The following is a description of a gene set: Genes specific to BEC (blood endothelium cells) repressed in BEC by expression of PROX1 off adenovirus vector. Lymphatic vessels are essential for fluid homeostasis, immune surveillance and fat adsorption, and also serve as a major route for tumor metastasis in many types of cancer. We found that isolated human primary lymphatic and blood vascular endothelial cells (LECs and BECs, respectively) show interesting differences in gene expression relevant for their distinct functions in vivo. Although these phenotypes are stable in vitro and in vivo, overexpression of the homeobox transcription factor Prox-1 in the BECs was capable of inducing LEC-specific gene transcription in the BECs, and, surprisingly, Prox-1 suppressed the expression of approximately 40% of the BEC-specific genes. Prox-1 did not have global effects on the expression of LEC-specific genes in other cell types, except that it up-regulated cyclin E1 and E2 mRNAs and activated the cyclin e promoter in various cell types. These data suggest that Prox-1 acts as a cell proliferation inducer and a fate determination factor for the LECs. Furthermore, the data provide insights into the phenotypic diversity of endothelial cells and into the possibility of transcriptional reprogramming of differentiated endothelial cells. from publication Petrova TV, Mäkinen T, Mäkelä TP, Saarela J, Virtanen I, Ferrell RE, Finegold DN, Kerjaschki D, Ylä-Herttuala S, Alitalo K (PMID 12198161) species: Homo sapiens Human Gene Set: PETROVA_PROX1_TARGETS_DN, and this is the list of marker genes: MMP14, ZBTB18, TFEC, EMP3, ARHGDIB, LTBP2, LDHB, PFKM, SELP, GBP2, RGS4, PLA2G4A, FAP, FAM107A, NRP1, VCAN (NCBI Gene Id 7902), CAP2, MAPKAPK3, LY75, NRCAM, NUAK1, SRGN, SRPX, PRNP, ITGA5, GLCE, IGF2BP3, ARL6IP5, PDLIM4, IL32, NNMT, ICAM2, PLAU, PROCR, SLC38A6, LPXN, TCN2, MLLT11, SERPINE1, PRKACB, TANK, ANXA6, LYL1, TRAM2, CDH2, SMURF2, CD59, AXL, KRT7, CCL2, TRIM22, ARHGAP22, TNFRSF21, ADGRG6, IL6, BMP6